The following is a description of a gene set: studied in species Homo sapiens Human Gene Set: GOBP_NADPH_REGENERATION A metabolic process that generates a pool of NADPH by the reduction of NADP+., and this is the list of marker genes: ALDOB, PRPS2, DERA (NCBI Gene Id 51071), RPIA, ALDH1L1, RPTOR, NNT, TKT, SHPK, TIGAR, ALDH1L2, TP53, RPEL1, ACACB, G6PD, TALDO1, MTOR, IDH1, MLST8, H6PD, RBKS, ACO1, PGLS, PGD, RPE